The following is a description of a gene set: part of: Nuclear events mediated by NFE2L2 Reactome Pathway: NFE2L2 regulating inflammation associated genes Subpathway representing inflammatory genes regulated by NFE2L2. NFE2L2 plays a pivotal role in regulating inflammation directly (by regulating inflammation-related genes like CCL2, IL8) and indirectly (through the HO-1-NFKB axis). This role of NFE2L2 plays a role in inflammatory diseases and expands NFE2L2 role beyond the antioxidant system. species: Homo sapiens, and this is the list of marker genes: IL8, NFE2L2, CREBBP, EP300, CCL2, MAFK